Given this list of marker genes MT-ND4L, MIR5087 (NCBI Gene Id 100847044), MT-TR, SNORD95, MT-ND4, MT-TY, MT-ND5, NCOA7, RPS15A, MED22, WBP2, MALAT1, MT-ND3, NDUFV3, PARP2, RPL3, MT-RNR1, RACK1, LINC00431, PPP1R15A, WDR4, MT-TT, DDX39B, MT-TN, MT-TH, RNVU1-21, CRY2, ILF2 (interleukin enhancer binding factor 2), H3-3B, PRPSAP1, RPPH1, SNORD84, IFRD1, GP6-AS1, RPL7A, MT-TE, CCDC127, MT-TV, DDX39B-AS1, TSACC, SNORD43, CCT3, EEF1A1, MT-CYB, PLD6, GADD45B, DEAF1, MT-TF, LINC02568, SDHA, MT-RNR2, MT-TG, MT-TS2, MT-TL2, MT-TA, TUBB4B, SPTAN1, PHF14, VPS37B, TMEM80, MT-ND6, MT-TP, MT-TC, here is a description of the gene set: from publication Yevshin I, Sharipov R, Kolmykov S, Kondrakhin Y, Kolpakov F (PMID 30445619) species: Homo sapiens Human Gene Set: HJURP_TARGET_GENES Genes containing one or more binding sites for (HJURP) in their promoter regions (TSS -1000,+100 bp) as identified by GTRD version 20.06 ChIP-seq harmonization.